Given this list of marker genes PTCH1, WNT7B, WNT5B, GLI3, PTCH2, BMP2, KIF7, WNT9A, HHIP, WNT10B, WNT2, WNT9B, WNT1, WNT8A, WNT3A, SMO, BMP4 (NCBI Gene Id 652), WNT8B, WNT4, WNT16, WNT6, GLI2, WNT7A, GLI1, WNT10A, WNT3, WNT2B, SUFU, WNT5A (Wnt family member 5A), here is a description of the gene set: Pathway Definition from KEGG: PTCH1* // SMO -> (SUFU+KIF7) // GLI => (BMP2/4,HHIP,GLI1,PTCH,WNT) Human Gene Set: KEGG_MEDICUS_VARIANT_MUTATION_INACTIVATED_PTCH1_TO_HEDGEHOG_SIGNALING_PATHWAY Mutation-inactivated PTCH1 to Hedgehog signaling pathway. Pathway ID: N00010. Pathway type: Variant. Pathway class: nt06269 Basal cell carcinoma. species: Homo sapiens